The following is a description of a gene set: species: Mus musculus from publication Tabula Muris Consortium (PMID 32669714) Mouse Gene Set: TABULA_MURIS_SENIS_MARROW_NAIVE_B_CELL_AGEING, and this is the list of marker genes: Psma7, E330020D12Rik, Gapdh, Efhd2, Aldh2, Eif4e2, Esd, Grn, Dtymk, Birc5, Cyba, Rac2, Coro1b, Fth1, Adss1, Tnfaip8, Tyrobp, Antkmt, Txn1, Glipr2, Arpc3, Cirbp, Tmsb10, Glrx3 (glutaredoxin 3), H2-D1, Cycs (cytochrome c, somatic), AW112010, Lgals3, Creld2, Serbp1, Anxa2, Dok3, Hint1, Pafah1b3, Prdx5, Snrpa, H2-K1, Rps7, Znhit1, Cks1b, B2m, Lat2, Nkg7, Plp2, Aldoa (NCBI Gene Id 11674), Rtn4, Rps3 (ribosomal protein S3), Lyz2, Echs1 (NCBI Gene Id 97386), Rtraf, Mrpl12 (NCBI Gene Id 69758), Atp5mc2, Phpt1, Srm, Mdh1, Tomm6, Ramp1, Apoe (NCBI Gene Id 11816), Cnpy2, Vasp, Pycard, Fkbp8, Anp32b, Stmn1, Ifi27, Ifitm3, Cope, Rpl3, Atp5if1, Rbm3, Ddx39b, Prdx2, Lsp1, Eif5a, Psmc1, Ftl1, Cuta, Pkig, Cebpd (NCBI Gene Id 12609), Pfn1, Erh, Tex261, Ms4a3, S100a8 (S100 calcium binding protein A8 (calgranulin A)), Phb2, Psmb2, Creg1, Hsp90ab1, Vti1b (vesicle transport through interaction with t-SNAREs 1B), Ifitm1, Grb2, Emp3, Psmd4, Herpud1, Tmem254, Nap1l1, Pebp1, S100a1, Anxa5, Slpi, Rab5if (RAB5 interacting factor), Acot7, Psmc4, Arpc4, Cdkn2c, Ptprcap, Camp, Prelid1, Mpo, Ccdc124, Hpf1, Ciao2a, C1qbp, Sp110, Spcs2, Jchain, Mvb12a, Tecr, Cd72, Tmem222, Psmb9, Kcnn4, C1d, Lgals3bp, Uqcc2, Eef1d, Capg, Comt, Ube2a, Chmp2a, Nfe2 (nuclear factor, erythroid derived 2), Txn2, Sdf2l1, Idh2, Psma5, Vdac3 (NCBI Gene Id 22335), S100a9, Tle5, Psmd7, Lat, Txndc17, Rpl13, Mrpl51, Sub1, Psmb5, Xist, Jund, Ap1s1, Ctsb, Ndufs8, Flot1, Capzb, Reep5, Rrp1, Vps28, BC004004, Tomm20, Pomp (NCBI Gene Id 66537), Mtarc2, Psmb8, Psmb10 (proteasome (prosome, macropain) subunit, beta type 10), Tmed9, Prtn3, Ctsz, Psmd8, Vim, Eif3f, Sec11c, Akr1a1, Uqcrc1, Mrpl36, Tmem14c, Psmc5, Atp5f1d, Sf3b2, Tmem160, Psme2, Tbcb, Tmbim4, Ech1, Denr (density-regulated protein), Ndufb7, Acbd6, Cst3, Arpc1b, Sdhc, Adgrg1, Psme1, Blvrb, Ybx1, Ptms (NCBI Gene Id 69202), Nme1, Mrpl52, Hsd17b8 (NCBI Gene Id 14979), Atp5mc3, Ube2k, Atxn10, Pepd, Clic1, Eif3k, Copz1, Npm1, Snrpc, Vdac2, Cotl1, Ms4a6b, Tmem176b, Ldha, Mif, Npc2, Crlf2, Spn, Cdk4 (cyclin dependent kinase 4), Ssbp4, Ccdc115, Tyms, Slc25a3, Pa2g4, Mrpl58, Grina, Scand1, Rack1, Mdh2, Calm2, Nme2, Bscl2, Lamtor1, Hp, Ptma, Retnlg, Htatip2, Wdr89, Ndufa10, Tpi1, Cmtm7, Ap2s1, Bri3, Ubxn1, Tmem9, Sdhb, Itgb1, Tmem256, Adk, Cfl1, Gstm1, Rsu1, Snrnp70, Atp5po, Rpl6, Nop53, Trir, Elane, Rnaset2b (NCBI Gene Id 98070), Ndufa12, Commd3, Fkbp2, Etfb, Slc25a5, Rplp0, Bsg, Gadd45gip1 (growth arrest and DNA-damage-inducible, gamma interacting protein 1), Pold4, Wfdc21, Rpl13a, Mtdh, Ranbp1, Swi5 (NCBI Gene Id 98849), Plin3, Adrm1, Eif3i, Gsto1, Ifitm2, Rab4b, Phgdh, Itm2c, Psmc3, Atp6v0b, Cfdp1, Fcer1a, S100a6, Trappc6a, Lamtor4, Rps3a1, Lgals1, Cd9, Prr13, Lilrb4a, Syngr2, Exosc5, Emc7, Tmed3, Ptpn1 (NCBI Gene Id 19246), Csnk2b, Napsa, H1f0, Ndufv2, Psmb6, Nhp2, Itm2b, Arhgdia, Dnajc8, Litaf, Ms4a6c, Calm1, Vcf1